The following is a description of a gene set: This event has been computationally inferred from an event that has been demonstrated in another species.<p>The inference is based on the homology mapping from PANTHER. Briefly, reactions for which all involved PhysicalEntities (in input, output and catalyst) have a mapped orthologue/paralogue (for complexes at least 75% of components must have a mapping) are inferred to the other species. Reactome Pathway: Glutathione synthesis and recycling studied in species Mus musculus electronically inferred by orthology from the curated human pathway part of: Glutathione conjugation, and this is the list of marker genes: Ggt7, Ggt1, Chac1, Ggt5, Ggt6, Chac2, Oplah